The following is a description of a gene set: studied in species Homo sapiens from publication Chen Y, Wang X (PMID 31504780) Genes predicted to be targets of miRBase v22 microRNA hsa-miR-6846-3p in miRDB v6.0 with MirTarget v4 prediction scores > 80 (high confidence targets). Human Gene Set: MIR6846_3P, and this is the list of marker genes: VPS53, IRS2, EPHA7, NDUFAF6 (NCBI Gene Id 137682), SLC10A7, ABCD1, AP4B1, VCAN, SP5, CTPS1, ARK2C, NR3C1 (nuclear receptor subfamily 3 group C member 1), ARL4D, SPO11, MRAS (NCBI Gene Id 654181), SLC26A8, TNPO1, TCF20, C5orf15 (NCBI Gene Id 56951), PLS3 (NCBI Gene Id 5358), SETD1A (NCBI Gene Id 9739), GALNT7, LILRB1, BTNL8, GNE, DZIP3